Given this list of marker genes SNORD67, AMBRA1, FOLH1, OR4A18P, OR4A19P, OR4R1P, OR4S1, FNBP4, ARFGAP2 (ADP ribosylation factor GTPase activating protein 2), MIR5582, NOX4P1, C1QTNF4, ANKRD33BP3, TRIM51FP, RPL34P22, ATG13, LINC02685, LINC02704, OR4X2, RPL23AP63, MTCH2, CKAP5, PTPRJ, LARGE2, ACP2, TYRL, OR4C3, OR4C45 (olfactory receptor family 4 subfamily C member 45 (gene/pseudogene)), TRIM51DP, PRDM11, MAPK8IP1, LRP4, SLC39A13, MIR4688, LINC02690, OR4A40P, ALKBH3-AS1, OR4A44P, MIR7154, RPL7AP79, TP53I11, ALKBH3, OR4R3P, OR4A49P, OR4A45P, ANKRD33BP5, CBX3P8, PHB1P2, RNU5E-10P, CHST1, GTF2IP11, TRIM51G, OR4C48P, MDK (NCBI Gene Id 4192), ARHGAP1, ZNF408, EXT2, GRM5P1, OR4A47, UBTFL9, RN7SKP287, CREB3L1, ANKRD33BP2, MYBPC3, OR4X1, CD82-AS1, F2, MIR3161, SYT13, OR4C49P, LRP4-AS1, CHRM4, LINC02750, SLC35C1, ACCS (1-aminocyclopropane-1-carboxylate synthase homolog (inactive)), MIR3160-2 (NCBI Gene Id 100422825), MIR129-2, LINC02489, ENSG00000254514, PSMC3, ALX4, TRIM51CP, PTPRJ-AS1, PTPMT1, CTBP2P6, MIR670, CRY2, NDUFS3, TRIM77BP, ACCSL, OR4A1P, OR4A48P, MIR3160-1, PACSIN3, TRIM64C, PPIAP41, TRIM49B, UBTFL7, TSPAN18-AS1, OR4A42P, OR4C2P, RN7SL652P, RNA5SP340, C11orf96, CELF1, PHKG1P3, MIR6745 (microRNA 6745), CSTPP1, CD82, PEX16, LINC02710, SEC14L1P1, LINC02687, OR4B2P, MADD-AS1, OR4A43P (NCBI Gene Id 403249), TRIM53CP, NUP160, YPEL5P2, LINC02716, OR4C13, NR1H3, OR4C4P, KBTBD4, SLC39A13-AS1, SEPTIN7P11, RAPSN, MIR4487, PHF21A, OR4B1, FREY1, OR4C9P, SPI1, FAM180B, ENSG00000252427, HSD17B12, DDB2, FBLIM1P2, OR4C10P, ENSG00000255314, OR4C12, OR4A46P, ENSG00000254746, MADD, HARBI1, AGBL2, OR4C5, DGKZ, ENSG00000254519, TSPAN18, OR4A41P, MIR670HG, here is a description of the gene set: species: Homo sapiens Human Gene Set: chr11p11